Given this list of marker genes OMD, FMOD, ST3GAL3, ACAN, PRELP, OGN, KERA, LUM, here is a description of the gene set: Reactome Pathway: Defective ST3GAL3 causes MCT12 and EIEE15 part of: Diseases associated with glycosaminoglycan metabolism studied in species Homo sapiens CMP-N-acetylneuraminate-beta-1,4-galactoside alpha-2,3-sialyltransferase (ST3GAL3) mediates the transfer of sialic acid from CMP-sialic acid to galactose-containing glycoproteins and forms the sialyl Lewis a epitope on proteins which are required for attaining and/or maintaining higher cognitive functions. Some defects in ST3GAL3 result in mental retardation, autosomal recessive 12 (MRT12; MIM:611090), a disorder characterised by below average general intellectual function and impaired adaptive behaviour. Another defect of ST3GAL3 can cause early infantile epileptic encephalopathy-15 (EIEE15: MIM:615006), resulting in severe mental retardation.